Given this list of marker genes KCNE3, SCN4B, ATP2B4, RASA3, KCNV1, AKT1, ENSA, MCUB, MICU2 (NCBI Gene Id 221154), CABP2, ACTN2, KCNAB1, ARPP19, VAMP8, REM2, KCNMB2, NHERF1, CFTR, SNCA, CAMK2D, C8orf44-SGK3, WWP2, VTI1B, LRRC55, CACNG5, SMDT1, FXYD6, ANK2, SNTA1, FGF14, SLC5A3, KCNF1, AMBP, CABP5, STIM1, GEM, CLCN2, ATP1B1, ANKRD36C, CACNG8, FGF12, KCNAB3, CACNG6, SNF8, STX1A, GPLD1, PKP2, CACNG1, TMPRSS3, FXYD2, LAMP2, RSC1A1, RACK1, CACNG4, NEDD4, KCNV2, KCNS2, KCNB1, PRKACA (NCBI Gene Id 5566), NPY2R, RASA1, GRM2, SCN1B, SRI, PDZK1, KCNIP2, FKBP1B, PACSIN3, DPP6, FLNA, LYNX1, TMEM168, CHP1, CABP4, CACNB1, GPD1L (glycerol-3-phosphate dehydrogenase 1 like), AKAP9, CAV1, HFE, AMIGO1, ABCC9, NPY, CACNB3, SGK1, NOS1, TMC7, STX7, KCNS3, KCNE4, FXYD6P3, NRXN2, GRM3, CALM3, KCNK2, KCNG4, TSPAN13, FKBP1A, REM1, PHPT1, SLC30A1, FXYD7, CALM1, ADRB2, KCNAB2, SGK3, FGF11, TNNI3, STIMATE, AGT, BSND, SCN2B (sodium voltage-gated channel beta subunit 2), WNK3, ATP1B3, CACNG7, CNIH3, PTPN3, YWHAE, KCNS1, KCNG2, MICU1, CAV3, CLTRN, STIM2, PLN, ANO9, DPP10, GLRX, YWHAH, SCN3B, ATP6AP1, KCNMB1, ITPR1, FXYD3, SCLT1, KCNIP4, KCNE2, HAMP, GSTM2, FGF13, PRKG1, ACTB, KCNG1, KCNE1, ACE2, NRXN1, DLG1, HPCAL4, KCNE5, FHL1, KCNG3, PDE4D, SUMO1, LRRC38, MICU3, BCL2, RRAD, LRRC26, RANGRF, OXSR1, PDE4B, KCNMB3, ATP1B2, CRISP1, LRRC52, COMMD1, KCNIP1, WNK4, STOM, DRD2, NHERF4, ATP2A2, ATP2A3, CABP1, KCNIP3, STK39, KCNMB4, FXYD1, SGK2, STX8, PCSK9 (proprotein convertase subtilisin/kexin type 9), KCNB2, DRD4, CACNG2, CALM2, FXYD4, CHRNA7 (NCBI Gene Id 1139), PRKCB, LAMP1, NEDD4L, CACNG3, FXYD5, ANK3, here is a description of the gene set: species: Homo sapiens Binds to and modulates the activity of a transporter. Human Gene Set: GOMF_TRANSPORTER_REGULATOR_ACTIVITY